The following is a description of a gene set: Downstream signaling of activated FGFR1 Mouse Gene Set: REACTOME_DOWNSTREAM_SIGNALING_OF_ACTIVATED_FGFR1 species: Mus musculus, and this is the list of marker genes: Fgf2, Fgf1, Fgf3, Fgf20, Ptpn11, Kl, Pik3r1, Plcg1, Shc1, Frs2, Gab1, Fgf22, Grb2, Fgfr1, Flrt2, Fgf10, Fgf9, Flrt3, Fgf4, Fgf23, Fgf5, Fgf17, Kras, Fgf6, Hras, Frs3, Flrt1, Sos1, Fgf8, Pik3ca